The following is a description of a gene set: Progressively up-regulated from 8-48 h during differentiation of 3T3-L1 cells (fibroblast) into adipocytes. studied in species Mus musculus Mouse Gene Set: BURTON_ADIPOGENESIS_4 from publication Burton GR, Nagarajan R, Peterson CA, McGehee RE Jr (PMID 15033539) During cellular differentiation and development, it is recognized that many complex molecular mechanisms as well as precise patterns of differentially expressed genes occur in directing precursor cells toward a given lineage. Using microarray-based technology, we examined gene expression across the course of 3T3-L1 adipocyte differentiation. Total cellular RNA was isolated at times 0, 2, 8, 16, 24, 48, and 96 h following treatment with either standard hormonal inducers of differentiation; insulin, dexamethasone, isobutylmethylxanthine (IDX), or IDX plus trichostatin A (TsA), a histone deacetylase inhibitor and potent adipogenic inhibitor. cRNA was synthesized from cellular RNA and hybridized to high density Affymetrix MG_U74Av2 microarray gene chips containing 12,488 cDNA/Expressed Sequence Tags (ESTs) probe sets. From the IDX-only treated cells, all probe sets that were either unchanged or differentially expressed less than 2-fold throughout differentiation with respect to time 0 preadipocytes were excluded from further analyses. This selection resulted in a net of 1686 transcripts, 859 were increased in expression, and 827 were decreased in expression at least 2-fold across differentiation. To focus in on genes that were more specific to differentiation, the same analysis was performed on IDX plus TsA-treated non-differentiating cells and all probe sets from the IDX-only group that exhibited similar expression profiles in the non-differentiating TsA-treated group were excluded leaving a total of 1016 transcripts that were regulated only under differentiating conditions. Six hundred and thirty-six of these transcripts were elevated at least 2-fold and 380 exhibited a decrease in expression relative to time 0 preadipocytes. This group of genes was further analyzed using hierarchical clustering and self-organizing maps and resulted in the identification of numerous genes not previously known to be regulated during adipocyte differentiation. Many of these genes may well represent novel adipogenic mediators and markers of adipogenesis., and this is the list of marker genes: Snrpa1, Anxa8, Entpd6, Col6a2, Nhp2, Cct3, Nsun2, Abcf2, Ddx51, Fkbp4, Ifi207, Emc8, Plxnd1, Atp6v1f, Ppp2r1b, Col18a1, Eif2b1, Daxx, Angptl4, Cmc2, Nop2, Ldha, Agtr2, Mrps12, Bcl6, Uchl5, Col4a2, Glul, Ppm1g, Srebf1, St3gal4, H2ax, Col6a1, H19, Adipor2, Pole4, Rcl1, Zfp385a, Cse1l, Zfp706 (NCBI Gene Id 98236), Lsm3 (LSM3 homolog, U6 small nuclear RNA and mRNA degradation associated), Igfbp4, Idh3a, Ephb4, Rhou, Dpep1